Given this list of marker genes CD320, SDHAF1, TESK1, TRIM21, TOMM40, C6orf89, XCL1, COX6A2, RHOB, PYCR2, SNORA7A, CLDN7, ACAD9, OGN, SNX10, PARP8, ANGPTL4, LDAH (NCBI Gene Id 60526), JOSD2, STRADA, APOE, METTL8, RBBP4, VPS35, GAS2, IDUA, TNF, FANCG, MEF2A, UBR7, USP39, SLC19A1, NDUFS6, ENTPD4, PTGER2, CRNKL1, SLC1A5, SNN (NCBI Gene Id 8303), ABHD14A, PLA2G12A, BATF, TRPC4AP, RPS8, NNAT, AP1S1, DSP, TDP2, BRI3, MIOS, RHOQ, KLRG1, LYVE1, GGH, ISL1, DPYSL3, MYO6, PPOX (protoporphyrinogen oxidase), CD82, ALG3, CHL1, CMTR2, GTPBP4, ACTG2 (NCBI Gene Id 72), GART, C1QC, ARG1, MTIF2, FURIN, ILF3, RMND1, PTBP3, NHP2, MCM5, SUCLG2, HDAC1, PTPN11, HAT1, YBX1, LDLR, IPO7, NUMA1, TYROBP, RPL35, FPGS, AURKAIP1, CKB, WDR75, LECT2, PYGB, CNGA3, SEPTIN9, AIMP2, UNC45A, CDC6, PIM1, TBC1D1, CNN3, MRPS28, PADI2, BOP1, TMEM14C, ARHGEF3, EPB41L4A-AS1, DNAJC3, MT2A, DIAPH3, AKAP9 (NCBI Gene Id 10582), SLC18A3, KRTCAP2, XIAP, DNAJC15, GCOM1 (GCOM1, MYZAP-POLR2M combined locus), SERPINB5, RPL22L1, TNNI3, CYB5R4, DOCK5, SLC48A1, CHADL, ACADL, PPAN, ARFGAP3, CPT2, GCAT, KCTD12, NES, BLK, C8orf82, BANF1, KIF23, RPL7A, MAP7, SLC25A25, CCL2, SRP68, ZNF841, SET, C9, GCLM, FRRS1, MRPS7, AKR1E2, RENBP, COL14A1, S100A11, CD8B, LGALS3, MFF, SQOR, ETF1, PDK1, ACTR1A, XPO1, WDHD1, HAUS5, AGTRAP, CERS2, CD74, SRM, METTL1, NF2, PPP1R15A, HEPH, SLA (Src like adaptor), PPRC1, CDK11B, POLR2K, SORD, NME1, CD72, PKN2, CSF1, DNAJC2, SERPINB2, RASAL3, EIF2AK3, SPART, SNHG6, BRWD3, G6PD, SMNDC1, DPAGT1, THAP12 (THAP domain containing 12), SELL, JADE1, YY1, WRN, NUP85, MTFR1L, POLDIP3, CAPG, IGFBP3, RNASEH2C, SAA1, C1QA, PNP (purine nucleoside phosphorylase, NCBI Gene Id 4860), SDC1, GNA13, CNOT1, GEMIN5, here is a description of the gene set: IFN-gamma transcriptional responses in control and IFN-gamma primed primary human macrophages Human Gene Set: GSE1925_CTRL_VS_IFNG_PRIMED_MACROPHAGE_DN studied in species Homo sapiens Genes down-regulated in control macrophages: untreated versus primed by IFNG. from publication Hu X, Park-Min KH, Ho HH, Ivashkiv LB (PMID 16148108)